Given this list of marker genes RFC4, UBB, RPA3, CHEK1, RAD51D, EXO1, XRCC2, POLE, ATM, POLD1, MRE11, GEN1, RAD51B, POLK, RAD9B (RAD9 checkpoint clamp component B), RBBP8, RPA2, KAT5 (lysine acetyltransferase 5), PCNA, TOP3A, DNA2, POLE3, TOPBP1, SEM1, XRCC3, BRIP1, RAD9A, NBN, ATRIP, UBA52, ATR, RAD51, EME2, RPS27A, POLD3, EME1, RFC3, WRN, POLD4, RHNO1, SLX4, BARD1, POLD2, SLX1A (NCBI Gene Id 548593), RAD51C, RFC5, RAD17, SLX1B, RTEL1, RAD50, SPIDR, BLM, RMI2 (RecQ mediated genome instability 2), HUS1, POLH, POLE4 (DNA polymerase epsilon 4, accessory subunit), MUS81, FIRRM, BRCA2, BRCA1, RAD1, RPA1, RAD51AP1, UBC, PALB2, RFC2, RFC1, FIGNL1, RMI1, POLE2, here is a description of the gene set: studied in species Homo sapiens HDR through Homologous Recombination (HRR) Human Gene Set: REACTOME_HDR_THROUGH_HOMOLOGOUS_RECOMBINATION_HRR